Given this list of marker genes Smo, Src, Cyfip1, Cobl, Map2, Hsp90aa1, L1cam, Hsp90ab1, Cdkl5, Mapk8ip1, Ptch1, Taok2, here is a description of the gene set: The migrating motile tip of a growing nerve cell dendrite. studied in species Mus musculus Mouse Gene Set: GOCC_DENDRITIC_GROWTH_CONE